Given this list of marker genes CALR, SLC7A7, IRF2BP2, FAS, BCOR, RARA, MPL, TET2, FASLG, STAT3, FIP1L1, NABP1, CXCR4, RPS14, ABCB7, ASXL1, PML, STAT5B, CASP10, NPM1, ZBTB16, KIT, SRSF2, JAK2, TBL1XR1, NUMA1, PRKAR1A, SRC, here is a description of the gene set: A larger than normal amount or percentage of hematopoietic cells relative to marrow fat. Bone marrow hypercellularity Human Gene Set: HP_BONE_MARROW_HYPERCELLULARITY species: Homo sapiens